The following is a description of a gene set: Human Gene Set: MIR2277_3P from publication Chen Y, Wang X (PMID 31504780) studied in species Homo sapiens Genes predicted to be targets of miRBase v22 microRNA hsa-miR-2277-3p in miRDB v6.0 with MirTarget v4 prediction scores > 80 (high confidence targets)., and this is the list of marker genes: DHX40, SRSF8, CDC37L1, SRSF2, TRIM38, FKBP1B, TLCD4, CTBP1, UBR5, IGLON5, CCR2, CGNL1, TMEM65, CDKN1A, NRSN1, NUPR2, NTNG1